Given this list of marker genes SEMA3F, STAMBPL1, FBXW2, PCMTD1, MAP1LC3B, RMND1, PIP4K2A, HSPB1, SNX14, PIK3CA, LGALS12, TRIM68, ANK1, CCDC62, MGA, KRIT1, NFAT5, AREL1, EIF5, RNF111, SERINC3, ZNF106, AKT3, SYCP2 (NCBI Gene Id 10388), MCTP1, RHOA, PJA2, RNF103 (ring finger protein 103), ANKS1A, GRINA (NCBI Gene Id 2907), ATXN7L1, MDFIC, ARID3B, DXO, ZFYVE27, SKIL, TCF12, GPR37L1, MLLT10, IL11RA, FGR, CASS4, SLC2A1, SMIM19, MOB4, TAB3, CHCHD10, ARRDC3 (NCBI Gene Id 57561), BCAP31, FBXL8, RPRD2, ETV3, CTSB, SNX5, N4BP3, ZNF691, RAMAC, SPSB3, FAM50A, GNPTAB, GOLGA3, CRIP2, RAB3A, CCM2, KANSL1L, EMID1, ENDOU, LY6E, RDH5, MAST4, SIAH1, SPO11, SLC29A4, SPPL2B, FCHSD1, RREB1, POU2F2, TRIM34, SLC3A2, DGKE, ZC3H12D, TM7SF3, GAK, LRSAM1, RSBN1, WDR45, CES5A, DCLK2, PDP1, MBD2, GPR153, TSPO, ST7L, EDRF1, SETX, KLHL36, CD93, UVSSA (UV stimulated scaffold protein A), SPATA6, CHMP5, NACC2, ZNF619, AIF1L, ZMIZ1, PSENEN, GCGR, MAN2A1, HDAC5, MRC1, MYO1F, FYCO1, AP2A2, RAPGEF4, SGK3, RIPOR1, EPS8L1, FSIP1, OPN1LW, BRD9, PRKX, IQGAP2, CHIC2, RPL13A, IFT25, PRF1, RAB19, BMF, MACO1 (NCBI Gene Id 55219), NECAP1, SERPINB7, CA2, MLLT6, F10, MS4A3, CCNL2, PPP1R12A, MYOC, RALGDS, CNIH2, TF, COLGALT1 (collagen beta(1-O)galactosyltransferase 1), SIM2, SOAT2, SLU7, YIPF1, SIK3, MS4A7, HSD17B1, DDIT4, FCGR2A, PCIF1, SMAP1, SUB1, SERTAD2, ATG16L1, SFT2D2, ITGA6, KPNA1, DCLRE1C, FGD2, MYO1E, FGD6, CTNS, RETREG3, KLHL15, ZNF513, MFSD10, CHUK, ATXN1L (ataxin 1 like), PDE2A, DDX23, SCML4, KDM4C, SPG11, MED12, UBL5, AFTPH, INO80D, MPND, ARL4A, XPA, PRKAB1, DNAJC4, UBQLN2, ILDR1, TMEM175, ENTREP3, SLAIN1, IFT172, ITGB2, ATP13A2 (ATPase cation transporting 13A2), ARID4B, ZC3H11A, NSF, CAPNS1, PDE1B, HSD17B8, ACBD3 (acyl-CoA binding domain containing 3), TUT4, here is a description of the gene set: Human Gene Set: GSE41867_NAIVE_VS_DAY8_LCMV_ARMSTRONG_EFFECTOR_CD8_TCELL_DN from publication Doering TA, Crawford A, Angelosanto JM, Paley MA, Ziegler CG, Wherry EJ (PMID 23159438) Genes down-regulated in CD8 T cells: naïve versus effectors at day 8 after acute infection with LCMV-Armstrong. species: Homo sapiens During acute viral infections, naïve CD8+ T cells differentiate into effector CD8+ T cells and, after viral control, into memory CD8+ T cells. Memory CD8+ T cells are highly functional, proliferate rapidly upon reinfection and persist long-term without antigen. In contrast, during chronic infections, CD8+ T cells become “exhausted” and have poor effector function, express multiple inhibitory receptors, possess low proliferative capacity, and cannot persist without antigen. To compare the development of functional memory T cells with poorly functional exhausted T cells, we generated longitudinal transcriptional profiles for each.